The following is a description of a gene set: studied in species Mus musculus Genes with intermediate-CpG-density promoters (ICP) that have no histone H3 methylation marks in neural precursor cells (NPC). from publication Meissner A, Mikkelsen TS, Gu H, Wernig M, Hanna J, Sivachenko A, Zhang X, Bernstein BE, Nusbaum C, Jaffe DB, Gnirke A, Jaenisch R, Lander ES (PMID 18600261) DNA methylation is essential for normal development and has been implicated in many pathologies including cancer. Our knowledge about the genome-wide distribution of DNA methylation, how it changes during cellular differentiation and how it relates to histone methylation and other chromatin modifications in mammals remains limited. Here we report the generation and analysis of genome-scale DNA methylation profiles at nucleotide resolution in mammalian cells. Using high-throughput reduced representation bisulphite sequencing and single-molecule-based sequencing, we generated DNA methylation maps covering most CpG islands, and a representative sampling of conserved non-coding elements, transposons and other genomic features, for mouse embryonic stem cells, embryonic-stem-cell-derived and primary neural cells, and eight other primary tissues. Several key findings emerge from the data. First, DNA methylation patterns are better correlated with histone methylation patterns than with the underlying genome sequence context. Second, methylation of CpGs are dynamic epigenetic marks that undergo extensive changes during cellular differentiation, particularly in regulatory regions outside of core promoters. Third, analysis of embryonic-stem-cell-derived and primary cells reveals that 'weak' CpG islands associated with a specific set of developmentally regulated genes undergo aberrant hypermethylation during extended proliferation in vitro, in a pattern reminiscent of that reported in some primary tumours. More generally, the results establish reduced representation bisulphite sequencing as a powerful technology for epigenetic profiling of cell populations relevant to developmental biology, cancer and regenerative medicine. Human Gene Set: MEISSNER_NPC_ICP_WITH_H3_UNMETHYLATED, and this is the list of marker genes: PROKR1 (NCBI Gene Id 151012), TUBA3D, SHANK2, MOGAT1, LEP, PPIH, TSSK3, EPN3, S1PR4, H1-7, NCKAP5, KRT85, LYL1, COL6A2, CNMD, EPPK1, PAK6, PLEKHG4, ADAM33, PALM3, TNFRSF13C, EVPL, FOXS1